Given this list of marker genes PDE4DIP, KPNB1, DLG1, CEP120, LIMK2, EZR, RAB11A, NUMA1, TPPP, CLASP1, CENPJ, here is a description of the gene set: A process that is carried out at the cellular level which results in the assembly, arrangement of constituent parts, or disassembly of astral microtubules, any of the spindle microtubules that radiate in all directions from the spindle poles. Human Gene Set: GOBP_ASTRAL_MICROTUBULE_ORGANIZATION studied in species Homo sapiens